The following is a description of a gene set: Genes down-regulated in CD4 T cells: untreated versus TGFB1 and progesterone. Human Gene Set: GSE22025_UNTREATED_VS_TGFB1_AND_PROGESTERONE_TREATED_CD4_TCELL_DN We examined the global gene expression pattern of T cells regulated by progesterone to gain further insights into the regulatory mechanisms of progesterone. We found 325-347 cord blood T cell genes up or down-regulated by P4 in the presence or absence of exogenous TGFb1. Peripheral blood T cells were relatively unresponsive with only 30-genes regulated by P4. IL-6 receptor (IL-6R) expression was greatly down-regulated by progesterone in cord blood, but not PB, T cells. Overall, these differences in gene expression are consistent with the differential responses of cord blood and peripheral blood T cells to progesterone. To gain insights into the differences of progesterone and control dendritic cells, we performed a microarray study and found ~genes regulated by progesterone in dendritic cells. The gene expression information suggests that progesterone has the potential to alter dendritic cell responses to cytokines, chemokine production, and migration which in combination would control T cell differentiation. species: Homo sapiens from publication Lee JH, Ulrich B, Cho J, Park J, Kim CH (PMID 21768398), and this is the list of marker genes: MYO1B, PHACTR1, GLI1, DNAAF9, RUNX2, TADA3, THBS1, HOXC4, FUT3, ELF2, CYBB, PPP1CB, GSTA4, FGB, PTGER2, KCNA6, SRY, TRPV6, FEN1, H2AC13, KPNA1, EPO (erythropoietin), PDE4A, GABRB3, MUC7, NCR2, CACNA1C, RGS12, CDH19, GPR31, IRF5, PRKN, OLFM1, PLA2G5, PRAMEF12, HLA-DMB, ADCY6, GDF15 (growth differentiation factor 15), ACTN3, IRF1, PI15, NEUROD2, KIF2A, DDX6, PDE8A, RAD52, PLA2G1B, PART1, COX20 (cytochrome c oxidase assembly factor COX20, NCBI Gene Id 116228), MAGEA8, POU1F1, L1CAM, RSBN1, SPINK2, ATP1B2, CASQ2, SPINK4 (serine peptidase inhibitor Kazal type 4), FRZB, LPCAT3, NCKAP1, GBP2, NFKBIE, TTLL12, NFATC3, RBBP8, CTSF, CEACAM7, PHOX2B, RUFY3, NDUFV2, SLC17A2, POLB, SLCO1B1, MELTF, ESM1, ARPC1A, CDC25A, ATP1A3, LINC00837, ALOX12P2, ANXA1, TFF3, GUCY1B1, RANBP6, BAMBI, GCSH, TPD52L2, TRIM16, FOLR3, BST2, NRXN3, CCND1, MRC1, SLC22A2, GTF2A1, FRMPD4, KRT34, PRRX1, KRT20, ANXA10, AIM2, TACR3, ISG15, DDAH1, ANGPT1, LILRB4, F8 (coagulation factor VIII), FOXJ1, PCNA, RPGRIP1 (NCBI Gene Id 57096), BAIAP3, ITGB1BP1, OVOL1, EIF2S1, GRM7, LTA4H, GK, CDC14B, PCSK6, BTN2A1, XCL2, PLD3 (phospholipase D family member 3), HAL, EFNA3, USP34, NR1I2, NAMPT, CCL18, TP53BP2, ZNF250, ARHGEF12, VPS41, MED22, ADH6, TNNT2, SERPINB5, SAPCD1, FNDC3A, PPFIA2, KRTAP5-9, ATF5, CORO2A, VSTM4, GLYAT, GTF2IRD2, ST20, ERAP1, RS1, RAB11FIP5, SLC2A5, UBE2V2, MELK, SLC5A5, CARD8, TGFB3, ATP8A2, GGPS1, LCE2B, DYNLT1, SPTLC1, ASIP, ITCH, ZNF253, MAOB, FRMPD1, SERPINB2, C7, CPA1, MAPK4, CHAF1B, HSPA4L (NCBI Gene Id 22824), NDUFS1, CNTFR, PLK1, METTL18, CCT6B, LIPC, RBP3, HAX1, REST, ABCA12, CD302, TRPC2, HGFAC, C1S, KCNJ13, EFNB3, GPR15, MAF, LSM6, HDAC9, CRISP3, SIRPB1, CAMK1G, ACBD3, DNAH9, SIGLEC6